The following is a description of a gene set: studied in species Homo sapiens Any process that modulates the frequency, rate or extent of sodium-dependent phosphate transport. Human Gene Set: GOBP_REGULATION_OF_SODIUM_DEPENDENT_PHOSPHATE_TRANSPORT, and this is the list of marker genes: CRY2, SFRP4, CEBPB, ATF4, SLC34A1